Given this list of marker genes Crebbp, Rel, Cactin, Pycard, Traf3ip1, Nlrx1, Relb, Sirpa, Ppm1b, Yy1, Traip, Nlrc3, Morc3, Atg9a, Nmi, Ptprs, here is a description of the gene set: species: Mus musculus Mouse Gene Set: GOBP_NEGATIVE_REGULATION_OF_INTERFERON_BETA_PRODUCTION Any process that stops, prevents, or reduces the frequency, rate, or extent of interferon-beta production.